Given this list of marker genes ACBD6, PDE4D, SEC24C, GP1BB, MYH3, NEK1, ZBTB18, ZSWIM6, HDAC8, CDK13, PTCH2, KCTD1, HNRNPU, LMX1B, PITX2, RNU4-2, ADAMTS18, ANKH, SPOP (NCBI Gene Id 8405), ETFA, KAT8, TRAF7 (TNF receptor associated factor 7), HECW2, TYR, PIGU, OTUD5, STXBP1, DDX3X (NCBI Gene Id 730543), EFEMP1, ACTB (NCBI Gene Id 60), XRCC4, JMJD1C, KIFBP, KITLG, ANKRD11, NOTCH2, NOTCH3, UBE3B, COMT, MSL3, NRAS, TBX1, SLC26A2, IRX5, PRKAR1A, PURA, ESAM, RAB23, WDR35, SNX14, BRD4, KDM6A, PTH1R, DDHD2, ADH5, ALX4, COLEC11, ARL3, SUFU, TBL1XR1, EDNRB, ZFX, C2CD3, ETFB, KCNH1, FLNB, CDK10, ADAT3, LIG4, IFT52, ADAMTS2, CDH2, GLI3, EBP, RNF125, FBN1, VPS33A, RFX7, FGFR1, PPP1R21, COLEC10, ARVCF, MAP2K2, EXOSC1, GPRASP2, H1-4, FOXC1, FOXL2 (forkhead box L2), CHRNG, ZMYM2, GRIA1, ATRX, PIGL (phosphatidylinositol glycan anchor biosynthesis class L), MUSK, ACTG1 (NCBI Gene Id 71), B4GALT7, EDN3, DVL3, SOX10, FGFR2, CRIPT, CHST14, ATP6V1B2, TLK2, TWIST2, PQBP1, AGO1, KRAS, LZTR1, UBR7, FLNA (filamin A), IFT122, SNAI2, ANKLE2, USP9X, STAC3, KMT2A, HRAS, MID1, TFAP2A, KDM6B, HNRNPR, SKI, TBC1D2B, HHAT, CREBBP, COL3A1, KCNN3, DOCK7, MYOD1, MASP1, RPS6KA3, HIRA, ZNF148, RREB1, MAP3K7, CHD6 (chromodomain helicase DNA binding protein 6), CCNQ, BMP4, ETFDH, YY1, OFD1, KMT2D, COL18A1, NSUN2, NFIX, UFD1, MAFB, IFT43, GJA1, PIK3R2, CCND2, PIGQ, TAPT1, FOXP2, CDH11, NSD2, PLCB4, AFG2B, ALG9, IDH1, DSE (NCBI Gene Id 29940), EFNB1 (ephrin B1), MITF, GNB2, DDB1, PIK3R1, EFTUD2, DHCR24, AKT3, PTCH1, LMNA, PAX3, ZEB2, ZMPSTE24, TRPM3, here is a description of the gene set: Distance between the inner canthi more than two standard deviations above the mean (objective); or, apparently increased distance between the inner canthi. species: Homo sapiens Human Gene Set: HP_TELECANTHUS Telecanthus